The following is a description of a gene set: Mouse Gene Set: REACTOME_SIGNALING_BY_TGFBR3 species: Mus musculus Signaling by TGFBR3, and this is the list of marker genes: Arrb2, Inhba, Aph1a, Gipc1, Timp1, Arrb1, Aph1b, Tgfb1, Tgfbr3, Tgfbr1, Inha, Tgfbr2, Ncstn, Acvr2a, Psen1, Fgf2, Tgfb2, Psenen, Mmp16, Timp2 (tissue inhibitor of metalloproteinase 2), Mmp14